Given this list of marker genes C15orf61, MSANTD4, NRXN1, UGDH, CXCL5, FBXO33, ZFYVE16, SCEL (sciellin), RERG (NCBI Gene Id 85004), LINC03104, LIN28B, ASCC3, LTN1, BAG1, HYDIN, HSPA4L, SH3KBP1, FBXO21, ZMYM2, GOSR2, DLD, PROS1, TAFA2, TNPO1, PRKAA2, CA8, MOB1B, KCND2, MANEA, DDX5, SOSTDC1, SLC2A3 (NCBI Gene Id 94827), BCOR (NCBI Gene Id 57686), TAF5, NLGN1, FAN1, ZNF649 (NCBI Gene Id 65251), CISD2, STK32A, AHR, ELOVL7, ARAF, ASAH1, MBTPS2, FSHR, STOX2, SCARA5, LPAR1, SDHC, WIPI1, DUSP8, CDKN2AIP, SLITRK4, PKD2 (NCBI Gene Id 5311), TCEAL9, PHF14, FBXO36, PTER, DOCK5, RORA, PPP1R8, ITGAV, SPRED1, LEPROTL1, TAF5L, FYN, ABI1, CCL7, GRM6, PPIP5K2, CCSER1 (coiled-coil serine rich protein 1), KDSR, ZBTB20, ZNRF2, STON1, CSRNP3, RAB21, OPN3, FOXC1, FNDC3A, MLF1, LRRTM3, ABCC9, GABPA, SMURF1, CHD9, SLC2A13, CUL5, PHTF2, ADAMTS3, PPP4R2, DNAI4, THUMPD3, IPMK, TOR1A, UFSP2, CRISPLD1, PDZD8, JADE1, SNRNP27, TOX3, SLC16A7, PCOLCE2, STYX, APP, TMEM33 (transmembrane protein 33), NETO2, ARPC5, PSMA8 (NCBI Gene Id 143471), ITFG1 (NCBI Gene Id 81533), GUCY1A2, SLC4A10, BRWD1, NISCH, SUZ12, TRIM41, MTHFD2L, SPOCK3, TCF7L2, DOCK9, ACSM5, CCDC186, UFL1, YTHDF3, HNRNPR, GPATCH2, KRBOX5, SMIM15, CCDC68, NREP, C10orf88, CNTN3, ADGRE2, SLC25A31, CDIN1, SMC5 (NCBI Gene Id 23137), CCDC90B (coiled-coil domain containing 90B), MS4A7, GDAP2, PHIP, MZT1, KRT73, HECA, METTL8, RNLS, MCM8, TMEM64, KCNK10, SLC10A7, JAK2, PSMD5, AZIN1, UGT2A2, UGT2A1, NME7, ZNF391, MID2, NLK, KLHL2, ZBTB44, LAMA4, RC3H1, HMGA2, THSD4, TSTD3, PLAGL1, TRIM36, RBM26, ATXN2L, STXBP5, UBR7, HEATR5A, ZNF699, NDUFA5, ZNF331, SYAP1, CALML4, XRCC4, ANGEL2, ABO, ATP11C, SNX16, SLC7A11, SHOC2, RCOR3, B4GALT6, TPTE, ITGA4, EXOC7, JPH4, LRRC31, PDE11A, KRTAP4-1, CFAP300, SLC6A15, LPP, SPAST, GIMAP2, RAB11FIP2, ZNF678, ENSG00000277067, ERCC6L2, GYPA, SIM1, NR3C1, ADAMTS19, MMAA, OXR1, PGR, SPC25, PRKACB, DGKH, MDH1B, CNTN4, BCAP29, GCSH, DPY19L3, CALD1 (NCBI Gene Id 800), SHPRH (SNF2 histone linker PHD RING helicase), KCNA4, RNF44, PDE6D, EIF4E, MPZL2, C18orf63, DCLRE1C, ANXA5, RAB23, LINC03105, here is a description of the gene set: Human Gene Set: MIR380_3P Genes predicted to be targets of miRBase v22 microRNA hsa-miR-380-3p in miRDB v6.0 with MirTarget v4 prediction scores > 80 (high confidence targets). from publication Chen Y, Wang X (PMID 31504780) species: Homo sapiens